Given this list of marker genes SNX7, CALCOCO2, IL4, WAC, OPTN, AMBRA1, BNIP3L, WIPI1, HUWE1, SMCR8, DELE1, LARP1, RALB, ATP5IF1, RAB3GAP2, MAP3K7, MUL1, NOD2, SNX30, ATG2A, ELAPOR1, SPTLC1, HSPB8, TSC2, PIP4K2B, PRKN, CDC37, MAPK3, LRSAM1, HK2, TRIM32, SUPT5H, TRIM13, PRKAA2, FBXO7, RNF31, FYCO1 (NCBI Gene Id 79687), KAT5, PIP4K2C, KDR, BAG3, NOD1, SNX4, SESN3, PIP4K2A, WDR45, ADRB2, GBA1, WDR24, DCN, CDK5RAP3, UVRAG, CSNK2A1, EIF2AK1, BNIP3, PAFAH1B2, SIRT1, SESN2, DDRGK1, ULK1, ZDHHC19, HIF1A, SNX18, GNAI3, PIM2, VDAC1, SPTLC2, RUFY4, IRGM (immunity related GTPase M), UBE2A, SCOC, STING1, C9orf72, SLC25A5, STUB1 (NCBI Gene Id 10387), HMOX1, TBK1, PINK1, TOM1, BECN1, VPS13D, HTT, RAB3GAP1, LACRT, CERS1, UFL1, HDAC6, SH3GLB1, TOMM7, GPSM1, EPM2A, IKBKG, SESN1, MOAP1, SLC25A4, RIPK2, here is a description of the gene set: species: Homo sapiens Any process, such as recognition of nutrient depletion, that activates or increases the rate of macroautophagy to bring cytosolic macromolecules to the vacuole/lysosome for degradation. Human Gene Set: GOBP_POSITIVE_REGULATION_OF_MACROAUTOPHAGY